The following is a description of a gene set: species: Homo sapiens Targetable kinases differentially expressed between PDX and donor tumors from nine ovarian cancer patients. from publication Liu Y, Chanana P, Davila JI, Hou X, Zanfagnin V, McGehee CD, Goode EL, Polley EC, Haluska P, Weroha SJ, Wang C (PMID 31004097) Mouse Gene Set: LIU_OVARIAN_CANCER_TUMORS_AND_XENOGRAFTS_KINASES_DN A bioinformatics pipeline to separate donor tumor and mouse stroma transcriptome profiles was devised and tested. To examine the molecular fidelity of PDX versus donor tumors, the authors compared mRNA differences between paired PDX-donor tumors from nine ovarian cancer patients., and this is the list of marker genes: Mapk11, Pdgfrb, Stk17b, Akt3, Prkd1, Btk, Flt4, Pdgfra, Jak2, Dclk1, Jak3, Pik3cg, Kdr, Stk32b, Plk3, Csf1r, Itk, Acvrl1, Flt1, Ntrk2, Tek, Camk4, Lrrk2, Axl, Prkacb, Epha3, Hck, Lck, Fgr, Prkg1, Irak3, Tie1